Given this list of marker genes IL2RG, ZAP70, TLR8, CD40LG, ZBTB24, IL21R, CARD11, IKBKG, PDCD1, C1QB, PSMB10, here is a description of the gene set: An opportunistic disease caused by invasion of unicellular fungus Pneumocystis jirovecii. Transmission of P. jirovecii cysts takes place through the airborne route, and usually, its presence in lungs is asymptomatic. However, people with impaired immunity, especially those with CD4+ T cell count below 200/microliter, are still at risk of the development of Pneumocystis pneumonia due to P. jirovecii invasion. Symptoms induced by this disease are not specific: progressive dyspnea, non-productive cough, low-grade fever, arterial partial pressure of oxygen below 65 mmHg, and chest radiographs demonstrating bilateral, interstitial shadowing. Human Gene Set: HP_PNEUMOCYSTIS_JIROVECII_PNEUMONIA studied in species Homo sapiens Pneumocystis jirovecii pneumonia